Given this list of marker genes Slc29a1, Gba2, Prxl2c, Ppargc1a, Pglyrp4, Tspo, Ndufa2, Myh8, Extl2, Sult1c1 (NCBI Gene Id 20888), Alg5, Adal, Itih3, Uap1l1, Cltc, Tmtc2, Chst13 (carbohydrate sulfotransferase 13), Entpd7, Pglyrp3, Aqp11, Mtor, Bad, Dhodh, Fam20b, St6galnac1, Pdgfrb, Prkaca, Tigar, Rpia, Slc37a2, B3gnt4, Prkag1, Atp2b2, Dpagt1, Ndufs1, mt-Nd6, Ndufa12, Map7, Slc25a51, Hkdc1, Nudt10, Oard1, Lyg1, Nudt1, Pde4c, Gusb, Urah, Egf, Fut9, Pgap1, Myh6, Pdgfb, Mdh2, Npc1, Fbp1, Itih2, Adss1, Tet2, Ddit4, Gfus, Bloc1s6, Pde9a, Slc4a1, Stt3a, Pfkfb4, Ddost, Mgat4c, Bpnt2, Gucy2g, Ogdh, Fgf2 (NCBI Gene Id 14173), Galnt4, Sulf2, Chil5, Gnai3, Adcy3, Tmem59, Rrm2b, Sult1e1, Ednrb, Tyw3, Galnt18, Ndufa10, Galnt13, Acacb, Aga, Ndufb3, Abhd6, Xylt2, Cryl1, Fam3a, Rptor, Abo, B4galt2, Nt5m, Dut, Shmt1, Atp5f1c, Abcc5, G6pd2, Angpt1, Rpn1, Pfkm, Adamts12, Dhdds, Mgat3, Nudt4, Psen1, Pomgnt1, Vegfb, Necab3, Ndufa5, Dctpp1, Upp1, Gata1, Nmnat1, Pnp, Ndst1, Sord, Pate6, Slc10a7 (solute carrier family 10 (sodium/bile acid cotransporter family), member 7), Ndufs4, Dsel, Pigb, Amdhd2, Khk, Ier3, Golga2 (NCBI Gene Id 99412), Slc39a8, Ndufa9, C1galt1c1, Ogt (O-linked N-acetylglucosamine (GlcNAc) transferase (UDP-N-acetylglucosamine:polypeptide-N-acetylglucosaminyl transferase)), Eno3, Ndufb5, Gucy1b1, Nagk, Cbfa2t3, Papss1, G6pc1, Mdh1 (NCBI Gene Id 83566), B4galt6, Galm, Slc35d2, Bace2, Selenon, Fuom, Dguok, Dnph1, Pfkfb2, Ost4, Ugp2, Lipa, Entpd4b, Myh3, Foxk2, Adcy10, St8sia3, Sult2a7, St6galnac4, Slc25a10, Rab1b, St3gal1, Xdh, St3gal2 (ST3 beta-galactoside alpha-2,3-sialyltransferase 2), Gpc1 (glypican 1), Ndufa3, Tkt, Parp1, Zbtb7a, Cln6, Prkag2, Ndufs7, Prkn, Sdha, Akr1c19, Entpd5, Trp53 (transformation related protein 53), Atp5mf, Hprt1, Chil4, Alg2, Dad1, Atp5me, Dera, Shmt2, Sgsh, Gimap7, mt-Atp8, Chpf, Ampd2, Fbxo44, Pigc, Fignl1, Mgat4a, Itih4, Gcnt3, Eogt, Mmp12, Fcsk, Trim63, Alg13, Impdh1, Gmppb, Mogs, Chil6 (NCBI Gene Id 279114), Ramp1, Ndufv2, Galnt16, Porcn, Ugcg, Cemip, Alg3, Tpi1, Rbks, Abca7, Ppara, Arfgef1, Ndufb4, Gmppa, Nt5c3, Sphk2, Clpx, Hs3st3a1, Ndufa13, Pfkp (NCBI Gene Id 80680), Sult1b1, St6galnac3, Hyal3, St6galnac6, St6gal1, Hdac4, Mgat5b, Frey1, Pklr, Slc25a25, Nme4, Pofut2, Engase, St8sia5, Shpk, Dpm3, Stt3b, Ap2a1, Gk5 (NCBI Gene Id 320574), Foxc1, Nme3, Dhtkd1, Asgr2, App, Habp4, Entpd4, Alg11, B3galt9, Pigf, Ndst3, Rrm2, Uggt1, Gal3st3, Bcl2l1, G6pc2, Glce, B3gnt6, B4gat1, Neu1, Parg, Hexb, Nt5c2, Ndufa7 (NADH:ubiquinone oxidoreductase subunit A7), Pigv (NCBI Gene Id 230801), Atp5po, Taldo1, Chsy1, Psap, Nudt11, Insr, Csgalnact2, Pnliprp2, B3galnt1, Uckl1, Nppb, Crppa, Atp1a2, Prkcd, Dtymk, Gba1, Slc4a4 (solute carrier family 4 (anion exchanger), member 4), Hrh3, Ran, Sdhb, A3galt2, Fktn, Cacnb4, Slc35b2, Pigw, Adamts7, Gmpr2, B3glct, Mustn1, Galnt6, Ak2, Gcnt4 (glucosaminyl (N-acetyl) transferase 4, core 2 (beta-1,6-N-acetylglucosaminyltransferase)), Ndst2, Bmp2, Umps, Aldoa, Gapdh, Hk3, H6pd, Pmm2, Pigk, Pde7a, Gxylt1, Ctps1, Krtcap2, Nt5c1b, Akr1cl, Poglut1, Akr1c18, Gpat3, Pigyl, Aicda, Mlx, Fut8, Impdh2-ps, Fbxo27, Uchl1, Kat2b, Park7, Acan, Eno2, Trmt12, Rhoa, Pycr3, Erp44, Pigo, Dpm1, Slc2a6, Phlda1, Slc30a5, Pcx, Sult2a4, Hs3st4, Gucy2f, Gal3st2, Ppp2ca, Pomt1, Rrm1, Csgalnact1, Hyal2, Xylt1, Ifng, mt-Nd3, Nanp, Tcf7l2, Dnm1l (dynamin 1-like), Ucp2, Hs6st3, Ahcyl, Nudt5, Pigm, Gda, Rora, Ncor1, Uap1 (UDP-N-acetylglucosamine pyrophosphorylase 1), Sec1, Lipc, Pfkfb3 (NCBI Gene Id 269236), Eno1b, Tkfc, Uxs1, Slc35c2, Cmpk2, Bmpr1b, Atp5mg, Gtpbp1, Tnip1, Pgk1, Atp5mc1, B3galt4, Soat1, Sik2, Pgls, Poglut3 (NCBI Gene Id 76515), Ncstn, B3gnt5, Gpd2, Uox, Pth2, mt-Nd4, Gbgt1, Tyw5, Mlec, Pawr, Mlst8, Tgfb1, Nmrk2 (nicotinamide riboside kinase 2), Pnp2, Chst4, Ndst4, Eif6 (eukaryotic translation initiation factor 6), Poglut2, Srd5a3, mt-Nd4l, Abcc9, Mtch2, Pgap4, Galntl6, Ihh, Slc35a1, Rab23, Piga, Aatf, Tmtc3, Myog, Il1b, B3galt1, Derl3, Pomgnt2, Il4, Galk1, Lrrk2, St3gal6, Nans, Stat3, Alg8, Atp6v1b2, Mfn1, Galnt14, Cmpk1, Abcc6, Lcmt2, Akr1c14, Adcy6, Esrrb, Gnpnat1, B3galt2, Pgm3, Pign, Sult2a1, Chst7, St8sia1, Slc35d1, Nccrp1, Ldhc, Chil3 (chitinase-like 3), B4galt3, Fpgt (NCBI Gene Id 75540), Pid1, Nme2, Atpsckmt, Atp4b, Tmsb4x, Gfpt1, Pigt, Alg1, Opa1, Dolk, Nmnat2, Pde4a, Cmah, Pgap3, Gucy2c, Xxylt1, Abca2, Chst2, Samhd1, Prps1, Ahcy, Cox11, Has2, Ago2, Pgm2, Mgat4f, Hs2st1, Fbxo2, Manba, Rfk, Ctbs, B3gat3, Hs3st2, Chst14, Prpsap2, Chst8, Ndufb11, Eno1, Macrod1, Npr1, Itih5, Edn1, Cad, Chst11, Guk1, Man1a (NCBI Gene Id 17155), Hyal4, 4930568D16Rik, Plcb1, Chi3l1, Ak5, Tnfaip6, Adcy9, Slc2a10, Akr1c6, Ccdc134, Atp6-ps, Upp2, Ovgp1, Akr1b1, Mlxipl, Neu3, Efl1, Nme5, Adcy2, Pgd, Acer2, Il3, Aldh1a1, Enpp3, Fuca2, Gapdhs, Fa2h, Ube2j1, Hbegf, Pgk2, Necab1, Chst12, Alg6, Atp5f1d, G6pdx, Edem2, Renbp, Crem, Uck1, Man2a1, Hs6st2, Slc4a10, Gpi1, Tgds, B3galnt2, Gm2a, Trex1, Galnt1, Prkaa1, Pals2, Ndufb9, St6galnac2, B4galt1, Aldob, Pfkl, Pde1a, Nmrk1, Ostc, Oga, Dolpp1, Fkrp, B3gat2, A4galt, mt-Nd2, Chp1, Nfe2l1, Pofut1, mt-Nd1, Galnt10, Paics, Pigl, Map2k1, Slc2a4, Cbr4, Ndufb7, Aldh1a7, St6gal2, Chst10 (NCBI Gene Id 98595), Dck, Foxk1, Pkm, Galnt3, Ada, Pemt, Tmem260, Akr1c21, Gal3st1, Galns, Hs3st1, Lyve1, Pgam2, Man1a2, Adcy5, Ngly1, St3gal5, Chst9, Il33, Dse, B3gnt7, Gucy2e, Itgb8, Ola1, Uprt, Nt5e, Tyw1, Lyg2, Slc25a12, Aldoart1, Hsd11b1, Pde4d (NCBI Gene Id 320753), Tymp, Acot8 (acyl-CoA thioesterase 8), Nudt14, Gapdhrt2, Jak3, Adpgk, Jmjd8, Hpse, Plod3, Abhd10, mt-Nd5, Mtap, Dctd, Ndufb1, Nudt3, Fut1, Pde2a, Dhfr, Tk2, Ppard, Man1c1, Nudt15, Sult2a2, Fut7, Nme6, Pgm1 (phosphoglucomutase 1), Dcxr, Pde8a (phosphodiesterase 8A), Atp5pb, St8sia2, Chst1, Fis1, Atp5f1a, Chia1, Gykl1, Bcl2, B3galt6, Ids, Sult2a6, Pcsk6, Chst3, Rpn2, Entpd1, Gpd1, Adcy1, Nme7, Col6a1, Gpd1l, Lct, Pmm1, Chst5, Large1, Upb1, Itm2a, Atp5if1, Fut11, Atp5f1b, Hspa1b, Dnajc30, Sulf1, Pals1, Tet1, Qng1, Ak4, Stab2, B3gnt2, Pigx, B3galt5, Ust, Gpat2, Pfkfb1, Hs3st6, Ccnd3, Acp3, Gns, Fut10, Nudt18 (NCBI Gene Id 213484), Ext2, Nfkb1, Bpgm, Gart, Nudt2, Extl1, Alg9, Mdp1, Has3, Fbxo17, Ak9, Nt5c, Bmpr2, Rpe, Slc25a13, Acp6, Vcp, Prkag3, B4galnt3, Aldoart2, Galnt9, Gorasp1, Npr2, B4galt5, Alg12, Hyal6, Prps1l1 (NCBI Gene Id 75456), Myh7, Gcnt1, Htr2a, Ins2, Uck2 (NCBI Gene Id 98564), Ppat, Git1, Itm2b, Tyms, Cda, Prps1l3, Ccr7, Ndufs8, Man1b1, Ampd1, Cst3, Sdhd, Sult2b1, Adss2, Fuca1, Ndufa8, Ext1, Pigz, Cytl1 (cytokine-like 1), Gnpda2, Xylb, Smpd3, Tk1, Gcnt2, Aldoc, Hs3st3b1, St3gal4, Trip11, Galnt15, Cmas, Gk, Gne, Sccpdh, Nudt9, Arnt, Glb1, Mgat2, Aprt, Hk1, Gamt, Prkaa2, Ctsl, Ctps2, Myc, Ctns, Npl, Pigu, Lmf1, Ndufb10, Ndufb8, Pglyrp2, Galnt5, Cant1, Chit1, Tmem165, Slc51b, Ins1, Naga, Galnt17, Cdadc1, St6galnac5, Epha2, Large2, Galnt11, Kit, Sirt6, Tm9sf2, Nme1, Gck, Ndufv3, Gckr, Sult2a3, Dpm2, Hyal5, Atp5mc2, Galnt12, Pigg, Mgat5, 6430550D23Rik, Gucy1a1, Arsb, Flcn, Ccl21a, Chsy3, Cog7, B4galnt1, Tusc3, Mgat4d, Gal3st4, Th, Gnpda1, Adcy7, Pxylp1, Akr1c13, G6pc3, Mgat1, Man2a2, Nus1, Dpyd (NCBI Gene Id 99586), Ptger4, Ndufs3, Serpina1b, Atp7a, Src, B4galt7, Pygl, Stoml2, Pck1, Atic (5-aminoimidazole-4-carboxamide ribonucleotide formyltransferase/IMP cyclohydrolase), Pde10a, Sdhc, Ugt8a, Tmtc4, Gmps, Pomk, Cd44, Apcs, Ggta1 (NCBI Gene Id 99321), Gnptab, Cela1, Igf1, Tmem258, St8sia6, Dpy19l3, Atp5f1e, Magt1, B4galnt4, Tbpl1 (TATA box binding protein-like 1), Uggt2, Papss2, Pde5a, Alg14, Gcnt7, Ak3, Pglyrp1, Galnt7, Enpp4, Adcy4, Vangl2, Sult2a5, Ndufs2, Actn3, Nppc, Gmds, Akr1c20, Itpa, Cog3, Ndufb2, Ndufc2, A4gnt, Galntl5, Alg10b, Itm2c, Mpi, Spam1, Ganab, Ndufs5, Slc35c1, C1galt1, Nudt16, Pigp, Pfas, Ugdh, Enpp1, Il15, Rxylt1, Ctnnb1, Atp6v1b1, Chpf2, Lep, Rab1a, Ndufa1, Hexa, B3gnt3, Ndufb6, Bend3 (BEN domain containing 3), Nppa, Hif1a, Fut2, Dpys, Has1, Neu2, Mfsd8, Ampd3, Sult2a8, Hnf1a, Ndufa11, Edem1, Gal3st2c, Prpsap1, Akr1c12, Letmd1, Ptx3, Adk, Trem2, Eno4, Atp5mc3, Hint1, Tmtc1, Rft1, Antkmt, St3gal3, Mppe1, Pigs, Pde7b, Rhoq, Hspa8, Fut4, Arl2, Akr1a1, Btk, Tmem106a, Cwh43, Cemip2, B3gnt9, Pcmt1, Itih1, Adsl, B4galt4, Idua, Pomt2, Gale, Tet3, Ndufc1, Impdh2, Hgsnat, Foxl1 (forkhead box L1), Dpy19l1, B4galnt2, Galc (NCBI Gene Id 78595), Pigq, Ndufs6, Ndufab1, Hs3st5, Bcl2l13, Ganc, Gnmt, Col11a1, Gfpt2, Gla, Dmac2l, Pyurf, Atp5pd, P2rx7, Ces2a, Atp5pf, Macrod2 (mono-ADP ribosylhydrolase 2), Extl3, Naglu, Gapdhrt, B3gnt8, Atp6v1a, Cfh (complement component factor h), B3gat1 (beta-1,3-glucuronyltransferase 1), Prps2, Slc2a1 (NCBI Gene Id 20525), Galt, St8sia4, Mgat4b, Slc9a1, Aoah, Pde8b, Gk2, Ptgdr, Rnaseh2b, Edem3, Fbxo6 (NCBI Gene Id 99978), Ndufa6, Urad, Ccl19, Gmpr, Adcy8, Ak1, Nupr1, Gxylt2, Atp1b1, Fn3k, Neu4, Gucy2d (guanylate cyclase 2d), Nagpa, Bax, Uqcc3, Pgam1, Hmmr, Golph3, Fbp2, Galnt2, Hk2 (NCBI Gene Id 15277), Ednra, Ndufv1, Ldhd, Atg5lrt, Trak2, Prkcsh, Mthfd1, Ep300, Hyal1, Serpina1a, Col2a1, Icmt, Pgap2 (NCBI Gene Id 97348), Gpaa1, Necab2, Hs6st1, Nt5c1a, Zbtb20 (zinc finger and BTB domain containing 20), mt-Atp6, Mgat4e, Pigh (phosphatidylinositol glycan anchor biosynthesis, class H), here is a description of the gene set: The chemical reactions and pathways involving carbohydrate derivative. species: Mus musculus Mouse Gene Set: GOBP_CARBOHYDRATE_DERIVATIVE_METABOLIC_PROCESS